The following is a description of a gene set: Human Gene Set: MIR6884_3P studied in species Homo sapiens from publication Chen Y, Wang X (PMID 31504780) Genes predicted to be targets of miRBase v22 microRNA hsa-miR-6884-3p in miRDB v6.0 with MirTarget v4 prediction scores > 80 (high confidence targets)., and this is the list of marker genes: CROT, MKX, POLR3F (NCBI Gene Id 115527), ATP11C, SH3GL2, NLGN1, UBE2E2, MTMR10, ADAM2, OSMR, UBTD2, FGF2, ANKRD50, PTP4A2 (protein tyrosine phosphatase 4A2), EMP2, NFYA, ZC4H2 (zinc finger C4H2-type containing), PGBD2, SDHAF2, ADAMTS5, GPAM, KCNE1, COPA, DSN1, RASSF3, DNAJC12, RPRD2, CDKN2AIP, ZBTB2, BATF2, MAN1A2, GAP43, RIMS2, TATDN2, LZTS3, EHD3, TNFAIP1, CA8, CARD14, MAN2A2, CTDSPL2, RARG, TEX29, ZC3H12B, DPYS, KIAA0232, TMEM165, NR3C2, XPO4, NPNT, PXYLP1, ATP2B1, MMD, CBL, YWHAG, NSD3, LARP4, SELPLG, HOXA1, DEGS1, MCFD2, ZNF800, SLC22A24, NUS1